The following is a description of a gene set: Representatives of the apolipoprotein B mRNA editing enzyme catalytic polypeptide 3 (APOBEC3) family provide innate resistance to exogeneous and endogenous retroviruses (see Cullen 2006 for a recent review). Humans and other primates encode a cluster of seven different cytidine deaminases with APOBEC3G, APOBEC3F and APOBEC3B having some anti HIV-1 activity. Our understanding is most complete for APOBEC3G which has been described first and the reactions described herein will focus on this representative enzyme.<br><br>APOBEC3G is a cytoplasmic protein which strongly restricts replication of Vif deficient HIV-1. It is expressed in cell populations that are susceptible to HIV infection (e.g., T-lymphocytes and macrophages). In the producer cell, APOBEC3G is incorporated into budding HIV-1 particles through an interaction with HIV-1 gag nucleocapsid (NC) protein in a RNA-dependent fashion. <br><br>Within the newly infected cell (= target cell), virus-associated APOBEC3G regulates the infectivity of HIV-1 by deaminating cytidine to uracil in the minus-strand viral DNA intermediate during reverse transcription. Deamination results in the induction of G-to-A hypermutations in the plus-strand viral DNA which subsequently can either be integrated as a non-functional provirus or degraded before integration. part of: Host Interactions of HIV factors species: Homo sapiens Reactome Pathway: APOBEC3G mediated resistance to HIV-1 infection, and this is the list of marker genes: gag, gag-pol, APOBEC3G, vpr, HMGA1, PPIA, rev, PSIP1, vif, vpu, BANF1